The following is a description of a gene set: studied in species Homo sapiens Any process that stops, prevents or reduces the frequency, rate or extent of cell proliferation involved in kidney development. Human Gene Set: GOBP_NEGATIVE_REGULATION_OF_CELL_PROLIFERATION_INVOLVED_IN_KIDNEY_DEVELOPMENT, and this is the list of marker genes: GATA3, WT1, FLCN, MIR125A, BMP4, BMP7